The following is a description of a gene set: The process in which an antigen-presenting cell expresses antigen (peptide or lipid) of endogenous origin on its cell surface in association with an MHC protein complex. species: Mus musculus Mouse Gene Set: GOBP_ANTIGEN_PROCESSING_AND_PRESENTATION_OF_ENDOGENOUS_ANTIGEN, and this is the list of marker genes: Ulbp1, H2-M2, H2-K1, H2-Q7, H2-Q6, H2-T5, H2-M9, Raet1d, H2-T13, H2-T23, H2-T22, H2-M10.3, Ide, H2-M3, H2-M1, 2410137M14Rik, H2-M10.4, H2-Q2, H2-T24, H60c, Tap2, Hfe, Cd1d2, H2-M10.2, H2-M10.1, H2-T3, H2-M11, H2-M10.5, Cd1d1, Atg5, H60b, H2-Ea, H2-M5, Azgp1, Tap1, Raet1e, H2-Q4, H2-T15, H2-Q1, H2-Q10, H2-M10.6, H2-D1, Tapbp, B2m